The following is a description of a gene set: Human Gene Set: MODULE_401 Genes in the cancer module 401. studied in species Homo sapiens, and this is the list of marker genes: LPL, CLC, PON1, PNLIPRP1, AOAH, BCHE, PLA2G10, PRDX6, AADAC, PLA2G2A, PLA2G5, CES1, APOC2, MGLL, LIPA, PLA2G7